The following is a description of a gene set: from publication Yevshin I, Sharipov R, Kolmykov S, Kondrakhin Y, Kolpakov F (PMID 30445619) species: Homo sapiens Genes containing one or more binding sites for (FOXR2) in their promoter regions (TSS -1000,+100 bp) as identified by GTRD version 20.06 ChIP-seq harmonization. Human Gene Set: FOXR2_TARGET_GENES, and this is the list of marker genes: TAF12, NIP7, THUMPD3, SLC39A9, TMEM258, TSC2, IPPK, COG8, BUD31, EIF2A, RSL1D1-DT, SUPT5H, CARS1, RPL34-DT, RPL34, EIF4A1, ENSG00000261840, SSR2, VIPAS39, ENSG00000227218, EIF2S3, SURF6, RPL27, PSMD9, DBNL, TCOF1, CWC22, RPS27, CD2BP2-DT, NSUN6, MTCO3P12, ABCF1, MRPS26, RPS17, ADPRM, TRMT112, MIR4519, MIEF1, PGK1, MTCYBP18, UBXN8, MT-CO1, CCDC71, IER2, MTND5P11, SRSF1, CNIH3, ADSL, RNF115, MTND5P10, CHERP, STX10, FTSJ3, NBPF1, EIF3L, SAMD10, MRPL27, TAF12-DT, MT-TP, SEC14L1, SCO1, PHF23, GTPBP4, EME1, RANBP1 (RAN binding protein 1), MT-ND1, SH2B1, GOSR2, SRP54, S100PBP, MT-RNR2, SNORD105, YRDC, P4HB, MRPL24, SASS6, FAM230G, LARS1, DUS3L (dihydrouridine synthase 3 like), C1orf122, RNU6-1, EIF2B1, MPDU1-AS1, RPS18, UQCC4, DPM2, NDUFB9, WDR18 (WD repeat domain 18), PRSS30P, SRGAP3 (SLIT-ROBO Rho GTPase activating protein 3), VPS52, IMPACT, POLR1B, MRPS23, UTP3, SEC23IP, CD2BP2, PIDD1, PRDX5, SUPT4H1, NUP35, YARS1, ING4, PCBP1, RPS14, UTP11, FADS2, TIMMDC1-DT, DHX8 (NCBI Gene Id 1659), TRMT13, PNKP, LUC7L, NR1H2 (NCBI Gene Id 7376), UBAC1, SRP54-AS1, CCDC9, MIR4754, MTHFD1L, RPS5, RSL24D1, WDR26, SECISBP2, SNHG17, RACK1, MED18, MTND4P24, ISG20L2, ITPA, EIF3I, SNORD95, DDX21, FKBP1A, EIF3M, RPS21-DT, DHX30, EIF1AD, AHSA1, RPS6, RPS16 (NCBI Gene Id 6217), SNHG21, ATP13A1, BABAM1, SERBP1, MED15, TIMMDC1, USF1, SLFN11, ANKRD54, C19orf53, RPL6, CCDC47, TRAPPC4, TXLNA, TRIM16, MT-TW, SERP1, UBE2G2, MT-ND4L, GOSR2-DT, TIMM10B, HM13, MRPL20, MCMBP, BANF1, FBXL19, MRPL43, GTF2H3, THOC5, SLC35E1, EIF3D, MT-TG, FEN1, RSL1D1, MCTS2, SNHG20, NOP16, EEF1A1, PDAP1, EXOSC4, MT-TQ, NTHL1, LINC01424 (long intergenic non-protein coding RNA 1424), MT-TR, RPL8 (ribosomal protein L8), RPS25, TRMT2A, MIR762HG, PPAN, HIGD2A, M6PR, ARFIP2, ZNF815P, PPAN-P2RY11, DNAAF5, ZNF202 (NCBI Gene Id 7753), SMUG1, KCTD5, SKIC2 (SKI2 subunit of superkiller complex), UFD1, SCARNA16, KTI12, KLRG1, LYPLA2, TATDN1, NELFE (negative elongation factor complex member E), METTL25B, RPLP2, GCN1, GPR137, ERH, TWNK, PCBP1-AS1, MT-ND4, MTND6P4, ZNF707, RPL32, MT-TL1, PRPF6, SFSWAP, TMEM234, FBXW11, ZNF384, CDC45, DDX42, PSMC5, PEX26, YKT6, POLR3C, RPS21, MT-ND3, TSR1, APPL2, STX4, KANSL1